Given this list of marker genes WSB1, BAIAP3, MAP3K12, SF3B1, EMILIN3, N4BP2, LPP, STAG2, CYP20A1, COMMD1, LIN52, SPPL2A, DNAL1, RSPH3, SP1, STX16, SLC25A36, F2R, SMIM14, LEPROT, SRSF10, CHURC1, MORF4L2, WASHC4, AGAP4, TRAK2, ANG, UFL1, GNB5, SNX9, POLK, ADD1, PWWP2A, RAD1, ZBTB38, APBB2, LACTB, SIAH1, BLOC1S6, ATG12, DNAJB14, SCAF11, C22orf39, TRIP11, FAM114A1 (family with sequence similarity 114 member A1), RSBN1L, INIP, KCTD20 (potassium channel tetramerization domain containing 20), SLU7, KLHL20, ICE2, DNAJC21, F8, GNB4, CREB1, ANAPC5, ATP6V1A, YIPF5, GINM1, PDP2, BMPR2, SLC17A5, ESR1, BBX, HEATR3, SLC35A3, BTD, FKBP14, MINDY2, here is a description of the gene set: PURPOSE: Amplification of chromosomal region 20q13 occurs in breast cancer but remains poorly characterized. EXPERIMENTAL DESIGN: To establish the frequency of 20q13 amplification and select the amplified cases to be studied, we used fluorescence in situ hybridization of bacterial artificial chromosome probes for three 20q13 loci (MYBL2, STK6, ZNF217) on sections of tissue microarrays containing 466 primary carcinoma samples. We used Affymetryx whole-genome DNA microarrays to establish the gene expression profiles of 20q13-amplified tumors and quantitative reverse transcription-PCR to validate the results. RESULTS: We found 36 (8%) 20q13-amplified samples. They were distributed in two types: type 1 tumors showed ZNF217 amplification only, whereas type 2 tumors showed amplification at two or three loci. Examination of the histoclinical features of the amplified tumors showed two strikingly opposite data. First, type 1 tumors were more frequently lymph node-negative tumors but were paradoxically associated with a poor prognosis. Second, type 2 tumors were more frequently lymph node-positive tumors but were paradoxically associated with a good prognosis. Type 1 and type 2 showed different gene expression profiles. No 20q13 gene could be associated with type 1 amplification, whereas several 20q13 genes were overexpressed in type 2 tumors. CONCLUSIONS: Our results suggest that amplified tumors of types 1 and 2 are two distinct entities resulting from two different mechanisms and associated to different prognosis. Genes up-regulated in non-metastatic breast cancer tumors having type 1 amplification in the 20q13 region; involves ZNF217 locus only. species: Homo sapiens Human Gene Set: GINESTIER_BREAST_CANCER_ZNF217_AMPLIFIED_UP from publication Ginestier C, Cervera N, Finetti P, Esteyries S, Esterni B, Adélaïde J, Xerri L, Viens P, Jacquemier J, Charafe-Jauffret E, Chaffanet M, Birnbaum D, Bertucci F (PMID 16899599)